The following is a description of a gene set: A process of protein insertion into the endoplasmic reticulum (ER) membrane in which a tail-anchored (TA) transmembrane protein is incorporated into an endoplasmic reticulum (ER) membrane. TA transmembrane protein, also named type II transmembrane proteins, contain a single C- terminal transmembrane region. Mouse Gene Set: GOBP_TAIL_ANCHORED_MEMBRANE_PROTEIN_INSERTION_INTO_ER_MEMBRANE species: Mus musculus, and this is the list of marker genes: Get3, Emc10, Bag6, Emc1, Caml, Get1, Emc7, Emc3, Get4, Emc4, Emc9, Emc6, Sgta, Emc8, Ubl4a, Emc2, Mmgt1